Given this list of marker genes ITFG1, DIPK1A, MAGEH1, NXPE3, ST6GALNAC4, PLAA, MAGED1, AIFM1, GSPT1, PIGK, SLC25A4, UFSP2, PIK3CG, MRPS7, IGLV4-60, RCN1, APMAP, APOBEC3B, GPX7, EMC9, ETNK1, SCO2, SEMA4A, NDUFAF1, DCPS, MOGS, PAPSS1, SPTSSA, KDELR2, GGCX, RPS6KB2, CENPU, LIME1, VCP, SURF1, ABCB9, IMPDH1, SLC39A7, BET1, MTDH, LAMP2 (NCBI Gene Id 3920), WIPI1, MRPL39, TOP2A, AARS1, KLF10, ANXA2P2, BAG2, GARS1 (glycyl-tRNA synthetase 1), MRPL17, IDH2 (NCBI Gene Id 3418), SS18 (SS18 subunit of BAF chromatin remodeling complex), NEK4, SKIC8, TYMS, CCPG1, TFG, NDC1, TMEM184B, TPP2, SSR3, NCBP1, ZBTB38, MAN1A1, FUT8, GFPT1, NT5DC2, RRBP1, FEN1, LPXN, MLEC, SHCBP1, SHMT1, PDK1, EPRS1, COPS8, CYTH2, DPP3, FNDC3B, GOLPH3L, FA2H, IGHA1, ZBP1, COMT, CCNB2, CDC20, MRPL57, PPIF, ACOT13, SMC2, ERCC2, NANS, EBP, AQP3, GLT8D1, ERAP1, CD14, SAC3D1, BOLA1, NDC80, TBL2, CDS2, EHD3, HIBCH, MGAT1, NUP37, NRBP1, TMEM208, NME1, LY96, RRM1, SEPTIN10, CCR10, CFLAR, NASP, CASP7, GADD45A, RPL26L1, MAGED2, ALG9, LGALS1, GPN2, DDB1, IGKV3-20, BHLHE41, MRPL13, C21orf91, CISD1, ISOC2, PPP1R14B (NCBI Gene Id 26472), CASP3, MTHFD1, HCCS, TXN2, SLC35B1, ACAT1, MZB1, PSMD1, SEC24D, PGRMC2, TRIB1, GBA1LP (glucosylceramidase beta 1 like, pseudogene), GOLT1B, ITM2C, LRRC59, GCN1, EIF2B2, CAV1, SPATS2, TYMP, LMAN1, MANEA, NDUFA6, ACOX1, SEC23B, BET1L, MRPS15, NCAPG, NUS1P3, SLC7A1, MRPL12, ENTPD1, PCCB, GGH, TMEM135, MVP, GMNN, CD38, CD58, DDX1, MBNL2, RAB27A, CLCC1, ARFGAP3, CTSC, FAM136A, DNM1L, MCM4, MCAT, PDCD5, KDELR1, CHST15, GMPPA, R3HDM1, MTRR, RUVBL1, CADM1, AVEN, RARS1, MAD2L1, ZBTB32, CNP, KIF11, FXN, TRAM2, IFI35, COCH, CCDC88C, here is a description of the gene set: Genes down-regulated in comparison of naive B cells versus blood plasma cells. from publication Abbas AR, Baldwin D, Ma Y, Ouyang W, Gurney A, Martin F, Fong S, van Lookeren Campagne M, Godowski P, Williams PM, Chan AC, Clark HF (PMID 15789058) Immune cell-specific expression is one indication of the importance of a gene's role in the immune response. In order to identify such patterns, we set out to broadly profile gene expression in a variety of immune cells. species: Homo sapiens Human Gene Set: GSE22886_NAIVE_BCELL_VS_BLOOD_PLASMA_CELL_DN